Given this list of marker genes CGGBP1, MAP2K5, DLG2, SOX12, SP3, GBF1 (NCBI Gene Id 8729), ING3, WASL, INTS3, IL2, TBC1D14, IST1, LMO1, APOLD1, ZBTB11, ANAPC7, BCL2L13, GEMIN4, HMGXB4, HOXA7, GNL3LP1, CRMP1, GARIN2, TSHZ1, ARHGAP29, CELSR3, DMD (NCBI Gene Id 548327), CNOT3, CRAT (NCBI Gene Id 1384), ZFAT, FKRP, PNPT1, CELF4, ZNF281, STRN4, CABP1, UFD1, ZNF41, DUSP7, SZRD1, MRPL24, CWC27, STAG1, CARMIL3, DUSP6 (dual specificity phosphatase 6), UBR3, RALGAPA1P1, PPP4R2, CDC45, TSC1, CAB39L, RSPH3 (radial spoke head 3), CCDC71, ENAH, PTCH1, MIR9-1HG, RUNX1T1, AP1G1, HIC2, MAP4K3, MGME1, NCAPH2, KCNJ9, SOCS5, C8orf82, CUX1, ADAMTSL1, PDE4D, GAS7, ABRAXAS2, NUFIP2, PAX6 (NCBI Gene Id 5080), TPGS2, AEBP2, SNX5, EPHA2, CSNK1A1, FOXN3, ZBTB48, NR2F1, ESM1, OSBPL6, NR2F2, BMAL1 (basic helix-loop-helix ARNT like 1), TAOK2, TMED10, SCAF8, SYNCRIP, SNX13, RECK, LMF2, SPRED2, ABL1, RBM14 (NCBI Gene Id 96086), SRSF1, MPC2, SREK1IP1, here is a description of the gene set: Human Gene Set: KMCATNNWGGA_UNKNOWN from publication Xie X, Lu J, Kulbokas EJ, Golub TR, Mootha V, Lindblad-Toh K, Lander ES, Kellis M (PMID 15735639) Genes having at least one occurrence of the highly conserved motif M116 KMCATNNWGGA in the regions spanning 4 kb centered on their transcription starting sites. The motif does not match any known transcription factor binding site. studied in species Homo sapiens Comprehensive identification of all functional elements encoded in the human genome is a fundamental need in biomedical research. Here, we present a comparative analysis of the human, mouse, rat and dog genomes to create a systematic catalogue of common regulatory motifs in promoters and 3' untranslated regions (3' UTRs). The promoter analysis yields 174 candidate motifs, including most previously known transcription-factor binding sites and 105 new motifs. The 3'-UTR analysis yields 106 motifs likely to be involved in post-transcriptional regulation. Nearly one-half are associated with microRNAs (miRNAs), leading to the discovery of many new miRNA genes and their likely target genes. Our results suggest that previous estimates of the number of human miRNA genes were low, and that miRNAs regulate at least 20% of human genes. The overall results provide a systematic view of gene regulation in the human, which will be refined as additional mammalian genomes become available.